The following is a description of a gene set: species: Homo sapiens Human Gene Set: MIR5591_5P Genes predicted to be targets of miRBase v22 microRNA hsa-miR-5591-5p in miRDB v6.0 with MirTarget v4 prediction scores > 80 (high confidence targets). from publication Chen Y, Wang X (PMID 31504780), and this is the list of marker genes: THRB, CLEC4E, MYCT1, DUSP23 (dual specificity phosphatase 23), ATPAF1, OR11A1, RHOBTB1, PTAR1, FOXP4, HMGA1, FLRT1, RASGRP3, RGR, ATP11A, ATP8A1, PRX, DHRS2, LAMTOR3, SPRYD4 (SPRY domain containing 4), PLXNA4, IPO13, NETO2, MYO9B, COL9A2, HIC1, KAT6A, LMX1A, NOA1, NPTX1, PML, ZNF22-AS1, TBXA2R, LY6G6C, KIAA0513, ZNF510, MICAL3, VPS36, MAP3K2, HECTD3, NUCB2, ABI2, PPP1R18, RAB9B, CBX6, CCDC157, SIRT2, PPFIA4, AK9, MYORG, CDK19, ST8SIA1, GINS2, FBXO10, ATP8A2, EDA2R, ZC2HC1C, SMCR8, USP54, NUMA1, OR7D2, STK36, SHPRH, TNRC6B, MBNL3, RBPMS2